Given this list of marker genes NEDD1, RABL2B, TUBE1, CEP192, TUBG2, TUBG1, BBS4, RAC1, LCK, TCP1, CEP85, CEP85L, NEK1, HOOK3, CDK5RAP2, DYNC2I1, TNKS, BBS9, PCM1, TNKS2, DYRK3, NIN, CEP152, here is a description of the gene set: studied in species Homo sapiens A network of small fibers that surrounds the centrioles in cells; contains the microtubule nucleating activity of the centrosome. Human Gene Set: GOCC_PERICENTRIOLAR_MATERIAL